The following is a description of a gene set: Analysis of the transcriptional response to SARS-CoV-2 compared with other respiratory viruses, including MERS-CoV, SARS-CoV-1 (SARS), human parainfluenza virus 3 (HPIV3), respiratory syncytial virus (RSV), and IAV. Genes up-regulated in IAV (A549 cells, MOI: 5, 9hpi) from publication Blanco-Melo D, Nilsson-Payant BE, Liu WC, Uhl S, Hoagland D, Møller R, Jordan TX, Oishi K, Panis M, Sachs D, Wang TT, Schwartz RE, Lim JK, Albrecht RA, tenOever BR (PMID 32416070) Human Gene Set: BLANCO_MELO_INFLUENZA_A_INFECTION_A594_CELLS_UP studied in species Homo sapiens, and this is the list of marker genes: PMAIP1, CISD2, RGS2, C1D, FBXW10, DHX58, FGFBP1, TMED7, CCL5, CCN2, IDI1, CPM, STC1, SRP9, MRPL42, DDIT3, MTFR1, CXCL8, IFIT2, EGR1, CCL2, DUSP6, LASP1NB, LINC00641, HBEGF, ANKRD1, ZFAND2A (NCBI Gene Id 90637), PLAUR, KLF10, CXCL5, HSPA5, NME1, TIMD4, NDUFC2, HERPUD1, NXT2, EREG, PYGM, THAP10, HSPA6, TMEM170B